The following is a description of a gene set: studied in species Mus musculus Mouse Gene Set: GOCC_COPII_VESICLE_COAT One of two multimeric complexes that forms a membrane vesicle coat. COPII is best characterized in S. cerevisiae, where the subunits are called Sar1p, Sec13p, Sec31p, Sec23p, and Sec24p. Vesicles with COPII coats are found associated with endoplasmic reticulum (ER) membranes at steady state., and this is the list of marker genes: Sar1a, Sec23b, Sar1b, Sec13, Sec31a, Cideb, Klhl12 (NCBI Gene Id 240756), Sec31b, Sec24a, Pdcd6, Sec24c, Sec23a, Sec24b, Sec24d, Pef1